The following is a description of a gene set: Human Gene Set: EN1_01 Genes having at least one occurrence of the motif GTANTNN in the regions spanning 4 kb centered on their transcription starting sites. This matches the EN1 transcription factor binding site V$EN1_01 (v7.4 TRANSFAC). species: Homo sapiens, and this is the list of marker genes: OSR1 (NCBI Gene Id 4955), ISL1, FOXP2, TMEM59L (transmembrane protein 59 like), SIPA1L1, PEX2, GAP43, TUT1, MORF4L2, NRAS, BDNF, RBFOX1, GNRH1, UBE2H, EOMES, ATP13A4, HOXB8, TFEB, MMP14, MAP4K4, NOTCH1, RPL38, IRX4 (iroquois homeobox 4), CD55, SAV1, GPC3, SREK1, MYOG, SH3BGRL2, PCDH9, SORBS2, CAMLG, FNDC3A, CWC15, SAT1, CTCF, CREM, HTR7, OTP, SYNJ2BP, FGF17, KDM6A, CLC, CDC14A, NRG1, OTX2, KLF15, RNFT1, FAM53C, HOXA11, FIBCD1, JAKMIP2, RAPGEF5, RNF39, HOXC11, KDM4D, ANK2, HOXD10, NKX2-2, ARL4C, TSHZ3, RDH10, RGS6, RUNX1T1, HOXA4, RAB2B, MITF, ELN (elastin), BCOR, LINC00173, TCF4, RARB, RNF43, ARHGAP6, LAPTM4B, NEO1, DLG2, GPC4, MAP3K5, NXF1 (nuclear RNA export factor 1), PTGR3, ATP9B, GRIA1, AFF4, DCDC1 (doublecortin domain containing 1), RBM4, CDX2, GRHL2, EYA4 (EYA transcriptional coactivator and phosphatase 4), SLC6A14, NPR3, FHL1, PAX6, NR4A3, TTC12, MAPK14, ERBB4, PLCB1, UTY, RTKN, PDGFRA, NOS1, FAM53B, PDZD2, GREM1, EFEMP1 (NCBI Gene Id 399564), RASSF9, IL1RAPL1 (interleukin 1 receptor accessory protein like 1), HOXD3, SLC6A9, LMO1